Given this list of marker genes NOP2, TRMT61B, METTL15P1, NSUN3, METTL25B, METTL15, TRMT2B (tRNA methyltransferase 2 homolog B), SPOUT1, BUD23, NSUN4, METTL16, MRM1, NSUN5, FBL, TRMT112, METTL5, FDXACB1, MRM2, EMG1, ZCCHC4, MRM3, TFB2M, FBLL1, TFB1M, FTSJ3, DIMT1, here is a description of the gene set: The posttranscriptional addition of methyl groups to specific residues in an rRNA molecule. studied in species Homo sapiens Human Gene Set: GOBP_RRNA_METHYLATION